The following is a description of a gene set: Any process that stops, prevents or reduces the frequency, rate or extent of chemokine (C-X-C motif) ligand 2 production. Mouse Gene Set: GOBP_NEGATIVE_REGULATION_OF_CHEMOKINE_C_X_C_MOTIF_LIGAND_2_PRODUCTION studied in species Mus musculus, and this is the list of marker genes: Oas1b (2'-5' oligoadenylate synthetase 1B), Oas1g, Oas1a, Oas1c, Oas3, Oas1d, Oas1e (2'-5' oligoadenylate synthetase 1E), Oas1h, Klf4, Map2k5, Oas1f